The following is a description of a gene set: Mouse Gene Set: GOBP_CEREBELLAR_PURKINJE_CELL_LAYER_FORMATION The process that gives rise to the cerebellar Purkinje cell layer. This process pertains to the initial formation of a structure from unspecified parts. The Purkinje cell layer lies just underneath the molecular layer of the cerebellar cortex. It contains the neuronal cell bodies of the Purkinje cells that are arranged side by side in a single layer. Candelabrum interneurons are vertically oriented between the Purkinje cells. Purkinje neurons are inhibitory and provide the output of the cerebellar cortex through axons that project into the white matter. Extensive dendritic trees from the Purkinje cells extend upward in a single plane into the molecular layer where they synapse with parallel fibers of granule cells. species: Mus musculus, and this is the list of marker genes: Atxn2, Cacna1a (NCBI Gene Id 12286), Foxp2, Psap, Atp7a (ATPase, copper transporting, alpha polypeptide), Cend1, Herc1, Skor2 (NCBI Gene Id 664805), Rora, Ttc21b, Gba1, Faim2, Agtpbp1, Slc25a46, Ttll1, Atp2b2, Lhx1, Lhx5, Whrn, Ldb1